The following is a description of a gene set: from publication Inamura K, Fujiwara T, Hoshida Y, Isagawa T, Jones MH, Virtanen C, Shimane M, Satoh Y, Okumura S, Nakagawa K, Tsuchiya E, Ishikawa S, Aburatani H, Nomura H, Ishikawa Y (PMID 16007138) Up-regulated genes discriminating between two subtypes of squamous cell carcinoma (SCC) type of non-small cell lung cancer: SSC-A vs SSC-B. Current clinical and histopathological criteria used to define lung squamous cell carcinomas (SCCs) are insufficient to predict clinical outcome. To make a clinically useful classification by gene expression profiling, we used a 40 386 element cDNA microarray to analyse 48 SCC, nine adenocarcinoma, and 30 normal lung samples. Initial analysis by hierarchical clustering (HC) allowed division of SCCs into two distinct subclasses. An additional independent round of HC induced a similar partition and consensus clustering with the non-negative matrix factorization approach indicated the robustness of this classification. Kaplan-Meier analysis with the log-rank test pointed to a nonsignificant difference in survival (P = 0.071), but the likelihood of survival to 6 years was significantly different between the two groups (40.5 vs 81.8%, P = 0.014, Z-test). Biological process categories characteristic for each subclass were identified statistically and upregulation of cell-proliferation-related genes was evident in the subclass with poor prognosis. In the subclass with better survival, genes involved in differentiated intracellular functions, such as the MAPKKK cascade, ceramide metabolism, or regulation of transcription, were upregulated. This work represents an important step toward the identification of clinically useful classification for lung SCC. Human Gene Set: INAMURA_LUNG_CANCER_SCC_SUBTYPES_UP studied in species Homo sapiens, and this is the list of marker genes: CD47, CS, CPSF2, MEAF6, DHFR, PRORP, CIT, PA2G4, P4HA1, SMNDC1, MCU, PATL1, P4HTM, WAPL